The following is a description of a gene set: The aggregation, arrangement and bonding together of a set of components to form an organelle. An organelle is an organized structure of distinctive morphology and function. Includes the nucleus, mitochondria, plastids, vacuoles, vesicles, ribosomes and the cytoskeleton. Excludes the plasma membrane. studied in species Mus musculus Mouse Gene Set: GOBP_ORGANELLE_ASSEMBLY, and this is the list of marker genes: Stam, Nbdy, Kif4, Gorab (NCBI Gene Id 98376), Tmem41b, Ngrn, Ift20, Bicd1, Trp53inp1, Cln3, Kcnq1, Cabcoco1, Dnah7a, Pacs2, Clcn4, Spata6, Nptx1, Cdkl5, Odad3, Usp10, Nf2, Poc1b, Syt7, Lrrc4b, Parva, Wnt5a, Tmem39a, Arl13a, Gsk3b, Limk2, Tmem175 (NCBI Gene Id 72392), Atg4a, Cep152, Map9, Prickle2, Ccdc28b, Trim32, Spg11, Rab20, Myom2, Rfx2, Rttn, Eif1a, Synpo2l, Rho, Chmp1b2, Wdr44, Rpgr, Msn, Eif2s1, Bccip, Dnhd1, Ehd3, Bloc1s6, Chmp1a, Irgm2, Cnot2, Syt1, Atxn2l, Snx18, Nrxn1 (neurexin I), Rc3h1, Vmp1, Acta1, Rangrf, Fbf1, Nsfl1c, Tcap, Gsn, Cd34, Zmynd12, Dynlt2b, Sec22b, Dnaaf11, Rpf2, Mapre3, Gtf2b, Pwp2, 1700012B09Rik (NCBI Gene Id 75481), Smcr8 (Smith-Magenis syndrome chromosome region, candidate 8 homolog (human)), Snx7, Garin1b, Cdc14a, Kcnf1, Rps14, Racgap1 (NCBI Gene Id 26934), Grb7, Ap5z1, Fhod3, Cfap221, Nop53, Rps27l, Rps15, Rab1a, Actl9, Fam209, Atg9a, AU040320, Nlgn1, Hoatz, Dcx, Sugt1, Gmnc, Rab7, Drc7, Igtp, Bbs10, Wdr35, Atg2b (NCBI Gene Id 78864), Avil, Flna, Fxr1, Htt (NCBI Gene Id 319350), Mir129-2, Mrm2, Rab33b, Rcc1, Wbp2nl, Tcirg1, Map10, Src, Spef1, Cep162, Atg16l1, Dhx29, Klc3, Atp6v1d, Actl7a, Rabl2, Ro60, Unc119b, Rnf5, Cfap47, Odf2, Cep290, Mtor, Farp2, Cetn2, Cep295, Deup1, Nme5, Fus, Cnot6l, Cfap43, Rilpl1, Chmp1b, Txndc15, Akt1, Kif3a, Golga2 (golgin A2), Ttc39c, Lama5, Pfn4, Xrcc5, Nphp3, Mypn, Kash5, Disc1, Mlh1, Synpo2, Mark4, Nup62, Pdcd6ip, Tgtp2, Rab33a, Tns3, Atg2a, Mfn2, Kif11, Npm1, Cep126, Kat2a, Ppp2r1a, Pdcl2 (phosducin-like 2), Gk2, Cyld, Garin3, Sh3pxd2b, Shank3, Gdi2, Myom1, Chmp5, Lrba, Vps13b, Rfx3, Nlgn2, Tbc1d12, Arl13b, Khdc3, Stag1, Noto, Arhgef9, Kntc1, Csnk1d, Kif9, Stx7, Odad1, Cfap20, Odad2, Dnah17, Ptk2b, Cnot1, Ntng2 (netrin G2), Poldip2, Ubxn2b, Senp6, Mir34c, Inpp5e, Bin2, Sac3d1, Diaph3, Ap1g1, Akap13, Wdr19, Rab8a, Luzp1, Septin2, Hspa1a, Tekt1, Ptprd, Gap43, Cript, Klhl41, Arhgef2, Tbpl1, Ahi1, Phf23, Csrp3, Evi5l, Flii, Cenpk, Mis12, Cep128, Tmem17, Il5, Plec, Enkd1, Cenpe, Rp1l1, Rpl5, Crocc, Fhdc1, Pqbp1, Tekt2, Prkdc, Tpx2, Becn1, Ssx2ip, Clxn, Smc3, Surf6, Fam161a, Efl1, Spice1, Meig1, Wrap73, Gm4841, Wdpcp, Dnaaf6rt, Atg9b, Ift172, Neat1, Dock7, Haus6, Atg4c, Bscl2, Mapk9, Ccno, Lmod3 (NCBI Gene Id 320502), Ccnb2, Tubgcp5, Gm12185, Sqstm1, Ulk1, Kifc5b, Ap1s1, Nebl, Cfap206, Rrs1, Ago2, Zdhhc12, Tmem67, Sipa1l1, Cfap298, Entr1, Haus7, Bop1, Ap3s1, Garin1a, Izumo3, Washc1, Eqtn, Vps4b, Cep63, Tapt1, Ptpdc1 (NCBI Gene Id 218232), Dnah5, Rdx, Cibar2, Saxo1, Dnai4, Eif6, Lcp1, Kif3b, Cds1, Prickle1, Dicer1, Rps23, Emc6, Arhgef5 (Rho guanine nucleotide exchange factor 5), Cfap100, Ubqln2, Nupr1, Cplane1, Ablim3, F830016B08Rik, Ythdf2, Zfp207, Lsm3, Plk2, Adamts16, Prkaa1, Chmp4b, 2700049A03Rik, Irgq, Haus1, Smc1a, Ccdc66, Cep97, Cby1, Cep135, Tekt5, Fuz, Sdc1, Ift74, Gabarap, Cdc20 (cell division cycle 20), Eral1, Rrp7a, Haus5, Aspm, Cfap119, Ift80, Pik3c3, Zfyve1, Wdr1, Hck, Poc5, Misp, Spag5, Traf6, Ythdf3, Cfap53, Fnbp1l, Csf2, Ino80, Micall1, Irgm1, Celsr3, Tmod3, Cenpj, Ap3d1, Chmp6, Zfp423, Rhoa, Casq1, Snap29, Srpx, Becn2, Cep89, Ccdc146, Mir449c, Crkl, Rb1cc1, Ap3m1, Lsm14b, Csmd2, G3bp1, Cep192 (centrosomal protein 192), Mterf3, D7Ertd443e, Drg1, Cluap1, Pdgfrb, Nptxr, Dnai2, Dnah7b, Neb, Tmem231, Tsg101, Hps5, Rpl10l, Ankrd23, B9d1, Tesk1, Cenpa, Pcdh15, Tbc1d30, B9d2, Tnnt1, Dync2h1, Ttc12, Spag6l, Smim22, Cplane2, Dzip1, Kctd17, Bbs7, Rpl11, Smad4, Fam149b, Iqcg, Fbxw8, Lrguk (NCBI Gene Id 74354), Pla2g3, Fgfr1, Coro1a, Tnnt2, Septin9, Cenpx, Sh3glb1, Pla2g4c, Slc9a8, Foxj1, Eif5, Fitm2, Tbc1d31, Rcc1l, Cavin4, Hdac3, Exoc5, Arl6, mt-Rnr2, Plk4, Arhgap35, Fsip2, Ralb, Srf, Ogfod1, Ccdc13, Ccp110, Atp2a2, Ift46, Myoz1, Dnaaf1, Armc9, Rnf4 (ring finger protein 4), Lpar1, Rfx4, Ccdc65, Dnah2, Bbs9, Elmod3, Tbc1d20, Ift25, Ccdc78, Stx17, Ccdc63, Pip4k2c, Tctn3, Tpm1, Cep19, Atxn2, Abraxas2, Hps6, Kif23, Ift57, Wee2, Ccdc42, Hps1, Hif1a, Atg3, Atg5, Incenp, 4933427D14Rik, Onecut1, Fscn1, Lrrtm1, Ccdc57, Pierce2, Dazap2, Hsf1, Trim37, Snf8, Spef2, Asb2, Wipi1 (NCBI Gene Id 74799), Cetn1, Cfap91, Six4, Nsun4, Mtmr3, Tctn1, Atg4a-ps, Alpk1, Aup1, Sclt1, Clasp1, C9orf72, Fitm1, Crk, Dnah7c, Rsph6a, Alkbh5, Ttll5, Washc5, Ttc21b, Zmynd10, Dnaaf5, Septin7, Eif2a, Ccdc88a, Cc2d2a, Ccdc113, D1Pas1, Kif27, Cav3, Myl9, Mef2a, Vps11, Rab19, Tmem237, Stk36, Chmp4c, Rps6-ps4, Sdc4, Marchf7, Lrsam1, Dnaaf2, Limd1, Ehd1, Trp53inp2, Caprin1, Birc5, Ccdc38, Cilk1, Lsm4, Mcidas, Synpo, Yif1b, Rps3, Lsm14a, Spag16, Sec23ip, Lrrtm2, Ccdc39, Zpbp2, Rufy4, Rabep2, Cibar1, Jhy, Ofd1, Pink1, Sqle, Haus8, Spaca1, Ctsd, Tbc1d21, Hydin, Pip4k2b, Ap3s2, Actr3, Cylc2 (NCBI Gene Id 74914), Grid2, Cep76, Arpc2, Atmin, Prox1, Ablim1, Mpv17l, Capn3, Cfap65, Lrfn1, Cetn4, Iqcn, Onecut2, Rpsa, Snx30, Rnf213, Ubqln1, Cep72 (NCBI Gene Id 74470), Tmf1, Mapre1, Rab11fip3, Ep300 (NCBI Gene Id 328572), Ube2b, Lmod1, Gpsm2, Scfd1, Mir34b, Adprhl1, Rab3ip, Ap1b1, Cfl2, Epm2a, Dync1h1, Spaca9, Tmem138, Ska2, Cltc, Lrrc23, Ccdc15, Nrxn3, E2f4, Atg7, Myh10, Arf4, Gas8, Bbof1, Gm12250, Nek1, Abraxas1, Hspa1b, Ska3, Rab43, Arhgef10, Cenpt, 9930111J21Rik1, Csde1, Ccdc61, Sox30, Ulk4, Ubxn10, Atg101, Wdr45, Nudcd3, Stx18, Rilpl2, Sdcbp, Liat1, Cfap161, Macir, Fsip1, Cfap97d1, Chmp2b, Ccdc103, P2rx7, Daw1, Dnaaf4, Cenpc1, Ppp1r35, Ift140, Cep350, Wnk1, Spink2, Bbs4, Rps25, Pafah1b1, Ift88, Ift43 (NCBI Gene Id 97842), Dbnl, Rps28, Casq2, Nme8, Cep120, Myh6, Mdm1, Poc1a, Abcb6, Chek2, Myl2, Ap1s3, Negr1, Cep131, Prkar1a, Ttll8, Tmem80, Cdc20b, Actc1, Jmjd6, Alms1, Neurl1a, Lrrc46, Ska1, Mylk3, Cfap157, Spag1, Pisd, Stag2, Acrbp, Pspc1, Usp9x, Numa1, Atg14, Wwtr1, Vil1, Caskin1, Pan2, Yap1, Bbs1, Togaram1 (NCBI Gene Id 328109), BC048507, Mospd2, Myo7a, Patl1, Erich3, Eif5b, Abcc4, Rnf186, Pdgfra, Cfap70 (cilia and flagella associated protein 70), Cds2, Ccdc96, Lzts2, Rpl24, Tmem216, Ttll1 (tubulin tyrosine ligase-like 1), Bmp10, Ambra1, Mybpc3, Pla2g5 (NCBI Gene Id 18784), Sting1, Lmod2, Eif4enif1, Chmp7, Pcm1, Tpgs1, Gorasp2, Dock5, Cfap58, Tnnt3, Haus4, Mphosph9, Haus3, Mtm1, Snhg15, Aurkb, Cbln1, Stx12 (syntaxin 12), Cfap74, Septin1, Plk1, Spag17, Prkaa2, Dync2i1, Notch1, Tgtp1, Rab17 (RAB17, member RAS oncogene family), Chn2, Mettl17, Cdca8, Ehmt2, Celsr2, Elapor1, Armc12, Hnrnpu, Cdk10, Cnot7, Mir449a, Smurf1, Ap1m1, Nip7, Tbc1d14, Mybl2, Rab3gap1, Kif2a, Clasp2, Edc3, Ubap2l (NCBI Gene Id 97055), Cfap69, Rab1b, Rps5, Kat2b, mt-Rnr1, Cep20, Ehd2 (NCBI Gene Id 259300), Eml3, Psen1, Krt8, Tekt4, Ttbk2, Tia1, Nop2, Hps4, Kifc1, Rab14, Dnali1, Cfap61, Arl3, Snx4, Tmod2, Misfa, Abca3, Cnot6, Ttll3, Cdkl1, Odad4, Atp6v0d1, Ppp2r1b, Kif15, Iigp1, Mcat, Mybpc1, Wipi2, Ehd4, Nkx2-5, Ccsap, Cep44, Atg4b, Ar, Slitrk3, Ndc80, Ddb1, Tubb5, Cfap73, Mef2c, Krt19 (NCBI Gene Id 16669), Rab39, Tmod4, Ephb2, Lrrc61, Wnk3, Cdc14b, Chmp3, Atg12, Ift56, Myom3, Rps27, Rsph4a, Tbc1d32, Mkks, Hyls1, Ocrl, Mapk8, Tubgcp4, Pls1, Patl2, Dlgap5, Tpr, Ift81, Aurka (aurora kinase A), Tmprss12, Tchp, Sdccag8 (NCBI Gene Id 76816), Rpgrip1, Armc2, Mybpc2, Abt1, Rab29, Ift27, Csrp1, Bbip1 (BBSome interacting protein 1), Dusp23, Ap1s2, Dcdc2a, Moap1, Edn1, Ncor1 (nuclear receptor co-repressor 1), Tekt3 (NCBI Gene Id 71062), Sptbn2, Agfg1, Noa1, Cep83, Rps6, Pcnt, Wdr45b, Prc1, Pikfyve, Uhrf1, Tubgcp3, Dnaaf3, Atg13, Dnal1 (NCBI Gene Id 74212), Mdn1, Ddx28, Ptprs, Rpgrip1l, Lats1, Traf3ip1, Ift122, Ulk3 (NCBI Gene Id 71742), Ulk2, Il1rap, Dnajb13, Cep250 (NCBI Gene Id 99368), Ddx6, Syne2, Pip4k2a, Cep164, Mrps7, Fez2, Lrfn4, Nek2, Tnrc6a, Kif24, Vdac3, Rsph1, Hdac2, Pkhd1, Hps3, Agfg2, Atg10, Rab32, Rpl38 (ribosomal protein L38), Elmod1, Dynll1, Pgm5, Rab7b, Pten, Dtnbp1, Dzip1l, Arfip2, Sbds, Rp1, Cenpw, Tubb1, Kcnj10, Snx10, Bbs5, Cdk5rap2, Actn2, Arl8b, Gfy (golgi-associated olfactory signaling regulator), Mrps2, Ttc8, Trappc14, Mzt1, Rab23, Mak, Ift52, Cfap410, Dnah1 (NCBI Gene Id 630521), Mterf4, Dync2li1, Mpv17l2, Tom1, Cylc1, Intu, Atg4d, Tubgcp6, Dnai1, Rps19, Ntrk3, Dhx30, Ak7, Spag6, Hap1, Cdk2, Noct, Iqub, Cenph, Zar1, Pibf1, Aaas, Chmp2a, Sass6, Ldaf1, Iqcb1, Dctn1, Mir449b, Kpnb1, Iigp1c, Sppl2c, Flnc, Vangl2, Ptpn23, Cep41, Tnf, Cfap54, Rbm14, Lima1, Dnai3, C1ql3, Map1lc3b, Stbd1, Abi3, Ift22, Pan3, Tmod1, Rab38, Stard9, C1qbp, Cntrob, Tbc1d7, Dhx37, Dcaf17, Rab34, Map1lc3a, Myoz2, Cep295nl, Rsph9, Ccdc40, Pum2, Csrp2 (NCBI Gene Id 13008), Cep70, G3bp2, Cc2d2b, Ccdc69, Cflar, Ap4m1, Mybph, Galnt11 (polypeptide N-acetylgalactosaminyltransferase 11), Asap1, Brix1, Fbxo5, Dnm2, Tctn2, Dync2i2, Gm5431, Syne1, Tubgcp2, Ccdc159, Mapre2, Ttn, Bcas2, Stil, Tmem107, Prkd1, Fbxo24, Nrap, Ubxn2a, Rab3gap2, Rab11a, Actg1, Trappc12, Fastkd2, Pln, Cirbp, Xirp1, Gabarapl2, Wdr11, Drc1 (dynein regulatory complex subunit 1), Ezr, Dnmbp, Dcaf13, Vps4a, C1ql2, Nectin2, Mapk15, Abi3bp, Nlgn3, Cfap44, Nrxn2, Abl1, Ift70b, Cfap57, Fez1, Ythdf1, Efnb1, Ccdc136, C2cd3, Styxl1, Atg16l2, Actr2, Lrrk2, Mns1, Dnaaf10, Ifi47, Odf2l, B3glct, Reln, Ldb3, Akap4, Haus2, Ddx3x, Wdr62, Ap3b1, Eif1ax, Dnaaf6, Neurl2, Itgb1, Fmr1, Atxn10, Gabarapl1, Fau, Bbs2, Ang, Dnah8, Myh11, Pierce1, Mrto4, Prrc2c, Cep85, Zpbp, Rilp, Wdr90, Mks1, Pogz, Mfsd14a, Ripor2